The following is a description of a gene set: species: Homo sapiens from publication Schaefer CF, Anthony K, Krupa S, Buchoff J, Day M, Hannay T, Buetow KH (PMID 18832364) Human Gene Set: PID_UPA_UPAR_PATHWAY Urokinase-type plasminogen activator (uPA) and uPAR-mediated signaling, and this is the list of marker genes: ELANE, SRC, FN1, FPR3, CTSG, VLDLR, MMP12, VTN, NCL (nucleolin), SERPINE1, PLAU, FGG, ITGAV, PLAUR, CRK, MMP9, LRP1, ITGA3 (NCBI Gene Id 4454), PDGFD, PLG, HGF, ITGB1, PDGFRB, ITGB3, FPR2, FPR1 (NCBI Gene Id 2357), ITGA5, FGB, EGFR, FGA, ITGB5, RAC1, MMP3, TGFB1, ITGAM, ITGB2, GPLD1, CTRC, BCAR1, KLK4, DOCK1, MMP13